The following is a description of a gene set: Mouse Gene Set: GOBP_REGULATION_OF_T_HELPER_2_CELL_CYTOKINE_PRODUCTION studied in species Mus musculus Any process that modulates the frequency, rate or extent of T-helper 2 cell cytokine production., and this is the list of marker genes: Rsad2, Il6, Arg1, Ifnb1, Prkcz, Cd81, Dennd1b (DENN domain containing 1B), Tbx21, Xcl1, Nlrp3, Gata3, Il4